The following is a description of a gene set: studied in species Mus musculus Mouse Gene Set: GOMF_TYPE_1_FIBROBLAST_GROWTH_FACTOR_RECEPTOR_BINDING Binding to a type 1 fibroblast growth factor receptor (FGFR1)., and this is the list of marker genes: Nptn, Fgf8, Fgf18, Fgf17, Fgf23 (fibroblast growth factor 23), Nrxn1